Given this list of marker genes MSX2, MSX1, NOTCH1, GALNT11, MKS1, ALPK2, here is a description of the gene set: studied in species Homo sapiens Human Gene Set: GOBP_CELL_SURFACE_RECEPTOR_SIGNALING_PATHWAY_INVOLVED_IN_HEART_DEVELOPMENT The series of molecular signals initiated by a ligand the binding to its receptor on the surface of a cell, which contributes to the progression of the heart over time.